Given this list of marker genes Ppp4r3c1, Ppp2r1a, Vrk3, Ppp2r5c, Sh3rf2, Ppp1r1c, Ptpa, Ppp1r27, Myoz1, Ppp3r2, Ppp2r2b, Calm1, Ensa, Ppp2r3a, Ppp2r5a, Calm3, Phactr1, Sirpa, Ppp2r5e, Tescl, Rcan1, Phactr3, Ywhae, Sbf2, Anp32e, Ppp1r12c, Tprn, Ppp1r12b, Ppp1r16b, Ppp4r2, Ppp4r3c2, Ppp2r1b, Ppp1r10, Ppp2r5b, Ppp1r9b, Bmp2, Ppp1r14c, Pabir2, Tmem225, Ppp1r1a, Elfn2, Csnk2a1, Ppp1r35, Ppp1r3b, Ppp1r16a, Ppp1r11, Ppp1r17, Sbf1, Ppp1r7, Cry2, Bmp2k, Ppp4r3b, Ppp1r14bl, Ppp2r2c, Cmya5, Rcan3, Elfn1, Ambra1, Styxl1, Phactr4 (phosphatase and actin regulator 4), Lmtk2, Igfbp3, Wbp11, Ppp4r4, Igbp1b, Ppp1r15b, Igbp1, Ppp1r14b, Tiprl, Ppp2r2d, 2810408A11Rik, Ppp1r8, Dmpk, Hsp90ab1, Ppp2r3d, Cip2a, Ppp3r1, Ppp6r3, Ppp6r1, Cnep1r1, Gna12, Arpp19 (NCBI Gene Id 72570), Ppp6r2, Ppp1r36, Smtnl1, Itga1, Ppp1r26, Ppp4r3a, Ppp1r1b, Ppp4r1, Ppp1r15a, Cabin1, Ppp1r37, Ppp2r2a, Ppp1r14a, Styx-ps, Tesc, Cdca2, Mgat5, Bod1, Ywhab, Calm2, Pabir1, Gtf2f1, Hsp90b1, Ppp1r12a (protein phosphatase 1, regulatory subunit 12A), Rcan2, Ppp2r5d, Uri1, Igfbp2, B3gat3, Ppp1r2, Ppp1r14d (protein phosphatase 1, regulatory inhibitor subunit 14D), Ptn, Cd33, Styx, Slc39a10, here is a description of the gene set: species: Mus musculus Binds to and modulates the activity of a phosphatase, an enzyme which catalyzes of the removal of a phosphate group from a substrate molecule. Mouse Gene Set: GOMF_PHOSPHATASE_REGULATOR_ACTIVITY